Given this list of marker genes AKR1C1, RDH16, RDH5, AKR1C3, HSD17B6, DHRS9, AKR1C2, AKR1C4, HSD17B10, here is a description of the gene set: studied in species Homo sapiens Catalysis of the reaction: NAD+ + androstan-3-alpha,17-beta-diol = 17-beta-hydroxyandrostan-3-one + NADH + H+. Human Gene Set: GOMF_ANDROSTAN_3_ALPHA_17_BETA_DIOL_DEHYDROGENASE_NADPLUS_ACTIVITY